The following is a description of a gene set: part of: Class A/1 (Rhodopsin-like receptors) electronically inferred by orthology from the curated human pathway Reactome Pathway: Hormone ligand-binding receptors This event has been computationally inferred from an event that has been demonstrated in another species.<p>The inference is based on the homology mapping from PANTHER. Briefly, reactions for which all involved PhysicalEntities (in input, output and catalyst) have a mapped orthologue/paralogue (for complexes at least 75% of components must have a mapping) are inferred to the other species. studied in species Mus musculus, and this is the list of marker genes: Gnrhr, Fshb, Cga (glycoprotein hormones, alpha subunit), Tshr, Gpha2, Gphb5, Fshr